Given this list of marker genes PTPN22, STAT4, PTPN2, NOD2, STUB1, CD247, HLA-DRB1, IL2RB, AIRE, IL2RA, ANKRD55, FAS, here is a description of the gene set: studied in species Homo sapiens Human Gene Set: HP_IRIDOCYCLITIS A type of anterior uveitis, in which there is Inflammation of the iris and the ciliary body. Iridocyclitis